Given this list of marker genes EDN1, RNF170, ITGA5, PIK3CA, BMP6, SCO2, ITGA2, FKRP, ALAD, ADSS1, RYR2, AGT, BNIP1, ABCG8, PRKN, MYOG, ITGB3, SELENON, TNS2, PPARGC1A, UQCRC1, TNF, MSTN, SOD2, ABCG5, HDAC5, BGLAP, ADSL, CYBA, COL6A1, HIF1A, CAPN3, ADIPOQ, ABCC9, SLC7A5, SLC38A2, CRY1, LEP, ATP5F1A, COL4A2, PRKAA2, PERM1, SMTNL1, KDM6B, FN1, CAT, CFL1, OXCT1, ANXA2, CBL, KL, DAG1, IL10, IL6 (interleukin 6), UCP3 (NCBI Gene Id 7352), GCG, PRKAG3, GCLM (NCBI Gene Id 2730), FNDC5, FIS1, CRY2, SRD5A1, PRKAA1, PHOX2B, RBP4, POSTN, PPARD, ITGB1, RARRES2, HSF1, HADH, BLOC1S6, GCLC, MMP2, METRNL, SLC25A25, CDK1, FOS, CAB39, FUT1, OXT, MIR762, CREB1, ANGPT2, here is a description of the gene set: Human Gene Set: GOBP_RESPONSE_TO_ACTIVITY Any process that results in a change in state or activity of a cell or an organism (in terms of movement, secretion, enzyme production, gene expression, etc.) as a result of an activity stimulus. species: Homo sapiens